The following is a description of a gene set: part of: Toll Like Receptor 3 (TLR3) Cascade species: Homo sapiens Receptor-interacting protein 1 (RIP1) mediates the activation of interferon-alpha/beta via intermediate activation of IKK/TBK1 or NFkB pathways. Reactome Pathway: TICAM1, RIP1-mediated IKK complex recruitment, and this is the list of marker genes: RIPK1, IKBKB, UBB, CHUK, UBA52, BIRC2, UBE2D1, BIRC3, UBE2D2, UBE2V1, RIPK3, UBC, TRAF6, IKBKG, TICAM1, RPS27A, UBE2D3, TLR3, UBE2N